Given this list of marker genes SV2B, CDKN1C, DLK1, LAPTM5, IGF1, here is a description of the gene set: studied in species Homo sapiens RIZ1 is a histone methyltransferase whose expression and activity are reduced in many cancers. In chronic myelogenous leukemia (CML), blastic transformation is associated with loss of heterozygosity in the region where RIZ1 is located and with decreased RIZ1 expression. Forced RIZ1 expression in model CML blast crisis (BC) cell lines decreases proliferation, increases apoptosis and enhances differentiation. We characterized molecular mechanisms that may contribute to potential CML tumor suppressor properties of RIZ1. Several RIZ1-regulated genes involved in insulin-like growth factor-1 (IGF-1) signaling were identified using cDNA microarrays. RIZ1 was shown to associate with promoter regions of IGF-1 and to increase histone H3 lysine 9 methylation using chromatin immunoprecipitation assays. IGF-1-blocking antibody was used to demonstrate the importance of autocrine IGF-1 signaling in CML-BC cell line viability. Forced RIZ1 expression in CML-BC cell lines decreases IGF-1 receptor activation and activation of downstream signaling components extracellular signal-regulated kinase 1/2 and AKT. These results highlight the therapeutic potential of inhibiting IGF-1 pathway in the acute phase of CML. Human Gene Set: PASTURAL_RIZ1_TARGETS_DN from publication Pastural E, Takahashi N, Dong WF, Bainbridge M, Hull A, Pearson D, Huang S, Lowsky R, DeCoteau JF, Geyer CR (PMID 16953217) Genes down-regulated in K562 (chronic myelogenous leukemia, CML) cells engineered to stably express RIZ1.